The following is a description of a gene set: Genes predicted to be targets of miRBase v22 microRNA hsa-miR-378h in miRDB v6.0 with MirTarget v4 prediction scores > 80 (high confidence targets). Human Gene Set: MIR378H from publication Chen Y, Wang X (PMID 31504780) species: Homo sapiens, and this is the list of marker genes: C4orf46, ZFPM2, NHSL3, GPR156, OPRM1, SULF1, NUAK2, CHAMP1, RAB10, OTUB2, AGK, VPS53, AHSA1, ELAC1, METTL4, ZNF124, KCNIP2, NPAS4, IQSEC1, NKX3-1, UHRF1, AK7, KLK4, WDR64, PTGES3, FCGR1A, RAN, RNF168, PLCXD2, PROK2, NR2C2 (NCBI Gene Id 7182), RPN2, NCAPG, FLT1, TSPAN17, CCNI2, CPD, CREBRF, JADE3, PIM2, PHC3, ATXN7L3B